The following is a description of a gene set: studied in species Homo sapiens from publication Chen Y, Wang X (PMID 31504780) Genes predicted to be targets of miRBase v22 microRNA hsa-miR-1278 in miRDB v6.0 with MirTarget v4 prediction scores > 80 (high confidence targets). Human Gene Set: MIR1278, and this is the list of marker genes: RTN1, GPR137B, STK17A, EIF1AX, SH3PXD2A, BMPR1A, RAPH1, BORCS7, TMEM64, TP53RK, ZNF704, TP63, PLXDC2, APPBP2, ZNF146, KLHL13, RUFY2, LRP2, FUT9, GRIA2, PALLD, ATP8A2 (NCBI Gene Id 51761), CNOT7, MYH10, HHIP, TP53INP2, CAPN6, STEAP2 (STEAP2 metalloreductase), CHORDC1, IQCA1, ZDHHC11, ZNF711, GEN1, POLK, RANBP9, ATL2, KLHL2, MSR1, KIF5B, RNPS1, DISC1, KLHL9, TAOK1, DPY19L3, ZNF750, ERBIN, CNTN4, IQCJ-SCHIP1, IL22, SPTLC1, ZNF417, DCD, SERAC1, RBL1, PSMB5, ARHGEF6, SMG1, DNAJC6, PASK, SRGAP2B, FXR1, ZBTB20, MKRN2OS, SRGAP2C, ZBTB43